Given this list of marker genes SOS2, IL3 (interleukin 3), PIK3R1, IL2RG, STAT1, JAK2, IL5RA, IL9 (NCBI Gene Id 3578), CSF2RA, PIK3CB, HAVCR2, GAB2, STAT5B, STAT3, JAK3, IL21R, IL15, LGALS9, JAK1, GRB2, INPP5D, IL9R, IL2, PIK3R3, IL15RA, PTK2B, PTPN6, STAT5A, INPPL1, IL2RB, LCK, CSF2, PIK3CD, IL2RA, PIK3CA, IL21, PIK3R2, STAT4, IL5, CSF2RB, SOS1, SYK, SHC1, IL3RA, here is a description of the gene set: part of: Signaling by Interleukins The interleukin-2 family (also called the common gamma chain cytokine family) consists of interleukin (IL)2, IL9, IL15 and IL21. Receptors of this family associate with JAK1 and JAK3, primarily activating STAT5, although certain family members can also activate STAT1, STAT3 or STAT6. studied in species Homo sapiens Reactome Pathway: Interleukin-2 family signaling